The following is a description of a gene set: Human Gene Set: GOBP_CELL_SUBSTRATE_JUNCTION_ORGANIZATION species: Homo sapiens A process that is carried out at the cellular level which results in the assembly, arrangement of constituent parts, or disassembly of a cell-substrate junction. A cell-substrate junction is a specialized region of connection between a cell and the extracellular matrix., and this is the list of marker genes: PTPRA, THSD1, SDC4, ITGA2, CDH11, CFL1, RAB8B, PTK2, POLDIP2, CAMSAP3, GREM1, TAOK2, EPB41L5, DUSP22, DMTN, ABL1, APOD, LIMCH1 (NCBI Gene Id 22998), SRC, ARF6, PLEC, PTPRJ, FAM107A, SLK, HRG, BCR, MAPRE2 (NCBI Gene Id 51683), ROCK2, GPM6B, TLN1, PEAK1, ITGB3, S100A10, VCL, CLASP1, ITGA5, TRIP6, TESK2, LAMA3, PHLDB2, MYOC, VEGFA, BCL2, ACTN1, ACTN3, MAP4K4, PIK3R1, ARHGAP6, DUSP3, EFNA5, MACF1, SLC9A1, RHOA (ras homolog family member A), PTPRK, MMP14, ACTN2, SFRP1 (NCBI Gene Id 6422), WDPCP, STON1, LAMC1, ARHGEF7, DAPK3, THY1, KDR, SORBS1, LDB1, ACVRL1, ACTG1, FERMT2, DLC1, TNS1, PPM1F, CORO2B, IQSEC1, NRP1, FN1 (fibronectin 1), DST, TSC1, ROCK1, COL16A1, RCC2, PIP5K1A, CLASP2, ITGB1BP1, LIMS1, WNT4, COL17A1 (NCBI Gene Id 7828), TEK, LAMTOR2, CTTN, RAC1, ITGA6, ITGB4, AJUBA, RHOD, SMAD3, THBS1, CORO1C, PTEN, EPHA3, PRICKLE1, WHAMM